The following is a description of a gene set: Mouse Gene Set: REACTOME_LAGGING_STRAND_SYNTHESIS Lagging Strand Synthesis studied in species Mus musculus, and this is the list of marker genes: Rfc1, Pola1, Dna2, Rpa1, Fen1, Pold4, Pold1, Lig1, Rpa3, Prim1, Rfc4, Pcna (proliferating cell nuclear antigen), Rpa2, Pold2, Rfc5, Pola2, Prim2, Rfc3, Pold3, Rfc2